Given this list of marker genes NCS1, ZNF550, YAF2, SLC46A1, KRAS, ERN1, TRIM9, MATN3, NKAIN2, ERRFI1, HOXD10, LUZP1, TPD52, F8, HECTD4, TNRC6B, MED30, ZKSCAN3, SLC9A6, HIPK1, DNAAF10, FBXO28, RPL7L1, LRRC40, PPP1R3D, HSDL2, ZSWIM5, SHC4, SRD5A1, C1orf21, AREL1, CEP85, MAX, HMBOX1, PRR23B, HOOK3, FLOT2, LPIN2, YY1AP1, ZNF423, TSPAN11, SLK (NCBI Gene Id 9748), USP16, HOXC8, MAPK9, ANKRD34A, FXN, SORBS2, ATG13, ADAMTS16, DBNDD2, SNX12, CD1E, JADE2, BACH1, CDC42 (NCBI Gene Id 998, cell division cycle 42), HSBP1, NAA50, MAT1A, MLLT11 (MLLT11 transcription factor 7 cofactor), NIBAN1, SLC25A44, LAMTOR1, PRICKLE2, GPC4, SYTL5 (synaptotagmin like 5), PNPLA1, SIGMAR1, CACNA2D1, EHF, KPNA1, TMEM263, KBTBD3, RERG, STAC, SEC24C, CPNE4, XBP1, NOVA1, TLR2, RPS6KA1, KIF1B, COLQ, ARL4C, SH3PXD2B, BCL11A, KANSL1, ITGB5, MIS18A, STK38, ZC3H7A, C2CD6, DOCK9, FNDC9, TREM1, BPTF, MPDZ (NCBI Gene Id 8777), NUCKS1, ZNF76, GDNF, P4HA1, NEK4, MTMR14, SNX1, MFNG, RAPGEFL1, LARP4B, MED15, LARP1, SPPL3, KLHL28, STK24, TRIM66, SEMA4F, ERG, SMAD1, CD200R1, RBM27, RAB11FIP1, MYH10 (myosin heavy chain 10), here is a description of the gene set: Genes predicted to be targets of miRBase v22 microRNA hsa-miR-6165 in miRDB v6.0 with MirTarget v4 prediction scores > 80 (high confidence targets). species: Homo sapiens from publication Chen Y, Wang X (PMID 31504780) Human Gene Set: MIR6165